Given this list of marker genes KRAS, FGF17, FGF9, FGF8, FGF23, NRAS, FGF16, FGF20 (NCBI Gene Id 26281), SHC1, FGF1, FGF4, FGF2 (NCBI Gene Id 2247), HRAS, FGF18, FGFR3, SOS1, GRB2 (growth factor receptor bound protein 2), FGF5, here is a description of the gene set: studied in species Homo sapiens Human Gene Set: REACTOME_SHC_MEDIATED_CASCADE_FGFR3 SHC-mediated cascade:FGFR3